Given this list of marker genes SMARCA4, BMP2, NSD2, CPLX1, FGFRL1, CHST11, CTBP1, APC, RBPJ, TBX5, SF3B4, WNT7A, DLX5, SALL4, EIF4A3 (NCBI Gene Id 9775), HOXD13, WNT10B, IHH, ROR2, ACVR1, SMOC1, KAT6A, GDF5, GLI3, KCNN3, NEK1, KCNJ8, ERF, VAC14, RIPK4, ARHGAP31, LETM1, CHSY1, GJA1, TPR, KCNH1, EOGT, ERI1, LRP4, FIG4, NELFA (NCBI Gene Id 7469), ABCC9 (NCBI Gene Id 102724274), NOTCH2, MGP, GPC4, NSDHL, HOXA13, NOTCH1, NOG, PIGG, ROBO1, DLL4, PUF60, PORCN, TRPV4, BHLHA9, LMBR1, BMPR1B, ARID1B, SALL1, FGFR1, DOCK6, FLNA, FGFR2, DACT1 (NCBI Gene Id 51339), PTHLH, ARSL, MAP3K20, LMNA, PIGF, here is a description of the gene set: Aplasia of a toe. That is, absence of all phalanges of a non-hallux digit of the foot and the associated soft tissues. Human Gene Set: HP_ABSENT_TOE studied in species Homo sapiens Absent toe